Given this list of marker genes PPIAL4F, PPIAL4C, PPIE, NKTR, PPIB, PPIAL4E, PPID, PPIAL4D, PPIH, PPIC, PPIA, PPIAL4A, PPIAL4H, PPIAL4G, PPIG, PPIF, here is a description of the gene set: Human Gene Set: GOMF_CYCLOSPORIN_A_BINDING species: Homo sapiens Binding to cyclosporin A, a cyclic undecapeptide that contains several N-methylated and unusual amino acids.